The following is a description of a gene set: Occular cell types curated from Gautam and Hamashima et al. Multi-species single-cell transcriptomic analysis of ocular compartment regulons species: Homo sapiens Human Gene Set: GAUTAM_EYE_CORNEA_FIBROBLASTS from publication Gautam P, Hamashima K, Chen Y, Zeng Y, Makovoz B, Parikh BH, Lee HY, Lau KA, Su X, Wong RCB, Chan WK, Li H, Blenkinsop TA, Loh YH (PMID 34584087), and this is the list of marker genes: RPS13, AKAP12, CEMIP, RTN4, EPB41L4A-AS1, ERF, RSL1D1, RPS25, MT-ND1, RPS17, B2M (beta-2-microglobulin), CEBPB (NCBI Gene Id 90277), EFEMP2, CLIC4, HIF1A, RACK1, NFAT5, RPS4X, PLIN2, ARHGDIA, NFIC (nuclear factor I C), CYB5R3, PLAC9 (placenta associated 9), PRRX1, A1BG, MYADM, PABPC1, MYLK, RPL4, THBS1, TPM2, MAGED2, NCL, ITM2C, PMEPA1, RAMP2, MTDH, ASAP1, IL6ST, COL12A1, SRRM2, COL8A2, FKBP11, PLD3, CCDC85B, MKLN1, EIF4B, DPYSL2, CDC37, JUND (JunD proto-oncogene, AP-1 transcription factor subunit), MT-ND3, MFAP4, MYL9, RPL21, IGFBP3, IFI16, FBL, TAF1D, NT5E, HLA-A, CLDN5, BRD4, LPP, RBPJ, MYOC, RPL18A, SON, TEAD1, RPS5, RPS16, TSHZ2, RPL8, SELENOP, EIF3D, SPATS2, TUBA1B, RPS20, PNRC1, ARMCX3, RPS3, FTL, WIPF1, RAB13, COL8A1, TSPAN4, SPTBN1, UBXN1 (UBX domain protein 1), HNRNPDL, RPL22, RBMS3 (NCBI Gene Id 27303), ERRFI1, RPL35, IL6, RPL29, RPS3A, C12orf57, TM4SF1, RPLP2, LTBP2, FERMT2, TSC22D3, IRS2, FBLN5, MAT2A, ATP1A1, ANKRD12 (NCBI Gene Id 55606), AKR1C2, RPL36AL, TLN1, ARGLU1, RPL11, BTG3, FBXO32, CXCL3, COL6A3, H1-10, RPL18, RCN1, ANKRD28, PNISR, CTHRC1, ITGBL1, PLOD2, IL1R1, RECK, PDLIM4, SHC1, PIK3R1, RPS9, FAM3C, TNS1, RPL36, RPL10, PPP1R1B, CTNNAL1, RPL35A, RHOC, HNRNPA1, SNCA, STC2, RPL13A (NCBI Gene Id 94020), GEM, RPS23, RPL36A, HLA-C, TFPI, RPS15 (ribosomal protein S15), SLC25A6, LAMC1, GOLGA4, TYMP, SMR3B, NUCB1, VAMP5, DNAJA1, FUS, LUZP1, SNHG32, CCDC80, ESD, CNN3, CD81, LAMB2, AAK1, TACC1